Given this list of marker genes MED21, ACER3, TTC1, NOL6, RND1, SNHG30, PFAS, MTO1, STAT6, KLHDC9, HEBP2, ALDOA, TRIM15, RRN3P1, CROCCP3, KAT8, LINC01235, IGSF21, MTFMT, FES, NCKAP1L, here is a description of the gene set: from publication Yevshin I, Sharipov R, Kolmykov S, Kondrakhin Y, Kolpakov F (PMID 30445619) Genes containing one or more binding sites for (ZNF404) in their promoter regions (TSS -1000,+100 bp) as identified by GTRD version 20.06 ChIP-seq harmonization. studied in species Homo sapiens Human Gene Set: ZNF404_TARGET_GENES